Given this list of marker genes APOE, APOA2, LDLR, APOB, APOA1, LPL, LCAT, APOC3, CETP, APOC2, here is a description of the gene set: Human Gene Set: WP_LIPID_PARTICLES_COMPOSITION Lipid particles composition studied in species Homo sapiens